The following is a description of a gene set: Human Gene Set: MIR609 Genes predicted to be targets of miRBase v22 microRNA hsa-miR-609 in miRDB v6.0 with MirTarget v4 prediction scores > 80 (high confidence targets). from publication Chen Y, Wang X (PMID 31504780) species: Homo sapiens, and this is the list of marker genes: MECP2, NFKB2, PLPPR5 (phospholipid phosphatase related 5), MYLIP, FXYD3, NDUFB4, SELP, RSPO4, ADARB2, SPMAP2, DENND1B, LY6G5B, PPP1R1C, GABBR2, RAG2, HNRNPK, NPR3, MBOAT4, HTATIP2, STARD9, FOXI2, SHOX2, TMCC1, ZKSCAN8, LSM12, GANC, CYBB, ADAM10, LARP6, ARHGAP32, PRKCI, USP8, MOSPD3, PIGM